Given this list of marker genes Edrf1, Hoxb1, Bicral, Cadps, Pabpc1, Insyn2a, Slc13a1, Epc2, Zfp770, Ocrl, Rai1, Sftpa1, Sox14, Arpc5, Nherf2, Arf2, Upf3b, Cd200r4, Sgsm1, Gja1, Map3k7, Azin1, Rbm12, St18, Gpr158, Vezf1, Zfp850, Kif5c, Cpne3, Cpsf6, Cyp2j13, Rala, Vip, Pmch, Nr1d2, Cacna2d1, Ranbp9, R3hdm1 (NCBI Gene Id 226412), Cyp2c40, Terf1, Sgpp1, Cbfb, Ndufaf4, Rfx7, Mef2c, Magi1, Isl1, Snca, Tnpo1, F13a1, Ptprf, Cyp2c68, Brdt, Neto1, Sash1, Ccar1, Cln8, Gm5148, Trp63, Fut9, Ccdc43, B3gnt3, Numb, Rap1a, Pisd, Mblac1, Marchf11, Gria4, Prickle2, Sdhaf3, Cep350, Ryr2, Mtm1, Relt, Cxcl17, Nepn, Gnpnat1, Akap10, Cpeb2, Nol7, Irx2, Spata31e2, Bcl11a, Mfsd4b1, Cmpk1 (cytidine/uridine monophosphate kinase 1), Diras2, B020004C17Rik, Kynu, Slc4a7, Grk5, here is a description of the gene set: Mouse Gene Set: MIR_6399 from publication Chen Y, Wang X (PMID 31504780) species: Mus musculus Genes predicted to be targets of miRBase v22 microRNA mmu_miR_6399 in miRDB v6.0 with MirTarget v4 prediction scores > 80 (high confidence targets).